The following is a description of a gene set: Reactome Pathway: Protein hydroxylation part of: Gamma carboxylation, hypusinylation, hydroxylation, and arylsulfatase activation This event has been computationally inferred from an event that has been demonstrated in another species.<p>The inference is based on the homology mapping from PANTHER. Briefly, reactions for which all involved PhysicalEntities (in input, output and catalyst) have a mapped orthologue/paralogue (for complexes at least 75% of components must have a mapping) are inferred to the other species. electronically inferred by orthology from the curated human pathway species: Mus musculus, and this is the list of marker genes: Rps6, Rccd1, Rpl27a, Drg2, Kdm8, U2af2, Jmjd4, Jmjd7, Riox1, Rps23